Given this list of marker genes Erbb2, Tnfrsf9, Cdkn2a, Ripk2, Il1b, Il1a, Tmem131l, Gnrh1, Tnfsf9, Clec4g, Foxp3, Bmi1, Shh, Ihh, Blm (Bloom syndrome, RecQ like helicase), Bmp4, Cd1d1, here is a description of the gene set: Mouse Gene Set: GOBP_REGULATION_OF_IMMATURE_T_CELL_PROLIFERATION Any process that modulates the frequency, rate or extent of immature T cell proliferation. species: Mus musculus